The following is a description of a gene set: Mouse Gene Set: REACTOME_NUCLEAR_ENVELOPE_NE_REASSEMBLY Nuclear Envelope (NE) Reassembly studied in species Mus musculus, and this is the list of marker genes: Ppp2r2a, Tuba1c, Lmna, Nup107, Lmnb1, Rcc1, Tubb6, Emd, Vps4a, Tubb4a (tubulin, beta 4A class IVA), Tuba1b, Nup43 (nucleoporin 43), Cdk1, Tuba8, Nup98, Ube2i, Tubb2b, Tuba3a, Tubal3, Chmp4b, Chmp7, Cc2d1b, Sirt2, Nup155, Chmp2b, Chmp4c, Sec13, Tuba3b, Ahctf1, Ndc1, Ankle2, Vrk1, Sumo1, Ppp2r1a, Chmp6 (NCBI Gene Id 69715), Vrk2, Chmp2a, Chmp3, Nup205, Tubb2a, Nup93, Banf1, Seh1l, Ccnb2, Pom121, Tubb3, Nup188, Tuba1a, Tuba4a, Nup37, Ppp2ca, Rangap1, Kpnb1, Tubb1, Spast, Lbr, Nup35, Nup85, Rbm39, Ist1, Tubb4b, Nup160, Ccnb1, Ran, Nup133